Given this list of marker genes GJA1, PALS1, CRB3, E, PATJ, TJP1, here is a description of the gene set: studied in species Homo sapiens Reactome Pathway: SARS-CoV-2 targets PDZ proteins in cell-cell junction part of: SARS-CoV-2-host interactions PSD95/Dlg1/ZO-1 (PDZ) domains are protein-protein recognition sequences, consisting of 80–90 amino acids that bind to a PDZ-binding motif (PBM), usually located at the end of the carboxy-terminus of a target protein (Hung AY & Sheng M 2002; Gerek ZN et al. 2009; Munz M et al. 2012). Proteins containing PDZ domains are typically found in the cell cytoplasm or in association with the plasma membrane and play a role in a variety of cellular processes such as cell-cell junctions, cellular polarity, and signal transduction pathways. The multidomain structure of PDZ-containing proteins enables them to interact with multiple binding partners simultaneously, thereby assembling larger protein complexes (Harris BZ & Lim WA 2001). Viruses also encode PBM-containing proteins that bind to cellular PDZ proteins. Viral PBMs target cellular PDZ-containing proteins involved in tight junction formation, cell polarity establishment, and apoptosis (Javier RT & Rice AP 2011).